The following is a description of a gene set: species: Homo sapiens Genes up-regulated in CD4 T helper cells Th17 treated with TGFB1 and IL6: 1h versus 60h. from publication Yosef N, Shalek AK, Gaublomme JT, Jin H, Lee Y, Awasthi A, Wu C, Karwacz K, Xiao S, Jorgolli M, Gennert D, Satija R, Shakya A, Lu DY, Trombetta JJ, Pillai MR, Ratcliffe PJ, Coleman ML, Bix M, Tantin D, Park H, Kuchroo VK, Regev A (PMID 23467089) Human Gene Set: GSE43955_1H_VS_60H_ACT_CD4_TCELL_WITH_TGFB_IL6_UP Despite their enormous importance, the molecular circuits that control the differentiation of Th17 cells remain largely unknown. Recent studies have reconstructed regulatory networks in mammalian cells, but have focused on short-term responses and relied on perturbation approaches that cannot be applied to primary T cells. Here, we develop a systematic strategy – combining transcriptional profiling at high temporal resolution, novel computational algorithms, and innovative nanowire-based tools for performing gene perturbations in primary T cells – to derive and experimentally validate a temporal model of the dynamic regulatory network that controls Th17 differentiation. The network is arranged into two self-reinforcing and mutually antagonistic modules that either suppress or promote Th17 differentiation. The two modules contain 12 novel regulators with no previous implication in Th17 differentiation, which may be essential to maintain the appropriate balance of Th17 and other CD4+ T cell subsets. Overall, our study identifies and validates 39 regulatory factors that are embedded within a comprehensive temporal network and identifies novel drug targets and organizational principles for the differentiation of Th17 cells., and this is the list of marker genes: SUPT6H, SGPL1, RAP1GDS1, IFNAR2, HSD3B7, ANGEL2, ZFP36, TNFRSF9, MNS1, UCK2, GYG1, MRPL37, S100A1, RYR2, GHRL, GBX2 (gastrulation brain homeobox 2), SSBP4, HINT1, RPS10, PSMB10, CDK16, RNF149, ADIPOR2, NLRX1, MYOC, ZFAND5, USF1, ATG5, PKM, RPL6, GSTM5, IL17A (NCBI Gene Id 94918), NFATC3 (NCBI Gene Id 82543), LIPE, FTH1, MAPK7, RPL23A, TOR2A, TMX1, ARHGAP45, FAM89B, MDP1, MAP2K4, MKRN2, MAPK1 (mitogen-activated protein kinase 1), GRB2, LSP1, BATF, SLC11A2, PTPN18, GABARAP (GABA type A receptor-associated protein), IDI1, SEMA3C, GSTT2, RGS10, TAX1BP1, KLHDC2, RAMP2, FARS2 (NCBI Gene Id 10667), PSMA4, VWF, TERF2, NHERF1, BRD8, MADCAM1, LPIN2, RALGDS, ATP6V1B2, FCGR2B, HCK, COQ7, CYTH3, PIK3CD, PSMC3IP, PFKFB3, RPL19, CAPZA2, XPOT, KLRD1, ASCC1, LGALS9B, PNKD, PJA1, GNAI2, AP2A2, CLDN7 (claudin 7), PRKCB, USP18, SH3GL1, ARG2, MEIG1, KIAA2013, SMS, DUSP16, GNAI3, MARCKS, ISG20, RPS18, LMBR1L, UBE2W, AIMP2, KDM5A, FAM32A, TRIM37, BBS9, PDRG1, EMC6, ACO2, MAP3K3, SPEF1, TAF10, SNX21, GORASP2, NR6A1, IRF8, XBP1, IER2, PCK2, ADM, LAMA2, NPEPPS, CD48, PDZK1IP1, HEXA, PLXNB2, KIAA0930, BCL6, TBXA2R, EPS8, CFH (complement factor H), SUPT4H1, SPHK1, EGLN2, LARP1, LAMTOR3, RELB, PUM2, CIAO2A, RAC2, MPP1, CLCN7, BRK1, TNFRSF4, HADHB (hydroxyacyl-CoA dehydrogenase trifunctional multienzyme complex subunit beta), CCDC6, PDE1C, IL6ST, ARF1, ISL1, ABCC3, VPS37B, DNAJB5, RACK1, GJA1, SLC27A1, PTPRCAP, RASSF2 (Ras association domain family member 2), ACAD9, ATP6V0E1, NAB1 (NGFI-A binding protein 1), JAK1, NFIB, LPP-AS2, VAPA (VAMP associated protein A), CEL, GNG2, ARPC1A, APAF1, SNTB2, TOR1AIP2, P2RY2, LDLR, DPYSL2, SIRPA, RAC3, RAC1, PIGS, PDPN, LIMD1, SIGMAR1, FCGR1A, TRIM46, GAB1, SAPCD1, STMP1, IKZF1, HDAC2, ACSL5, LDAH, MAP2K7, SNX2, SNX1, NAA40, TLE3 (TLE family member 3, transcriptional corepressor), LAMTOR2, ABCC1 (NCBI Gene Id 8133), TARBP2, LITAF, CSF3R, MAN1A1